The following is a description of a gene set: Genes predicted to be targets of miRBase v22 microRNA hsa-miR-3960, hsa-miR-8072 in miRDB v6.0 with MirTarget v4 prediction scores > 80 (high confidence targets). species: Homo sapiens Human Gene Set: MIR3960_MIR8072 from publication Chen Y, Wang X (PMID 31504780), and this is the list of marker genes: PCDHA9, PCDHA4, PCDHA1, SLC9A3, PCDHA12, PCDHA10, POU3F3, PCDHAC1, PCDHA8, PCDHA2, PCDHA7, PCDHA13, PCDHA6, WWP2, PCDHAC2, PCDHA5, PCDHA11, PCDHA3